Given this list of marker genes JAG1 (jagged canonical Notch ligand 1), DLL1, HES1, MSX1, NODAL, NKX6-3, NOTCH1, here is a description of the gene set: Human Gene Set: GOBP_INHIBITION_OF_NEUROEPITHELIAL_CELL_DIFFERENTIATION species: Homo sapiens Any process that prevents the activation of neuroepithelial cell differentiation. Neuroepithelial cell differentiation is the process in which epiblast cells acquire specialized features of neuroepithelial cells.